The following is a description of a gene set: The aggregation, arrangement and bonding together of a set of components to form a SNARE complex, a protein complex involved in membrane fusion; a stable ternary complex consisting of a four-helix bundle, usually formed from one R-SNARE and three Q-SNAREs with an ionic layer sandwiched between hydrophobic layers. studied in species Homo sapiens Human Gene Set: GOBP_SNARE_COMPLEX_ASSEMBLY, and this is the list of marker genes: SNCA, VPS18, VPS8, UVRAG, VPS16, LRRK2, VAMP4, VAMP8, VPS39, STXBP1, SEPTIN8, TGFBRAP1 (transforming growth factor beta receptor associated protein 1), STX1A, VAMP2, VAMP3, CLTRN, VPS41 (VPS41 subunit of HOPS complex), STXBP6, STX4, PRRT2, VAMP1, VPS11, ANKRD27, VPS33A